Given this list of marker genes INPPL1, RAP1B, GNG10, RNF103, ADD3, ALDH1A1, AHCYL1, ETS2, PCMT1, ARL3, PHOX2A, CALB1, DHX8, ARHGAP11A, YES1, HMGN2, SRSF11, CTH, ARPC5, PIM1, OSBPL9, RPL27A, RAB31, PKNOX1, GTPBP1, VIM, CDK7, MAFG, NLK, HNRNPU, MAN2A2, ST13, SERINC1, MYB (NCBI Gene Id 4602), CELF1, here is a description of the gene set: from publication Dorsam ST, Ferrell CM, Dorsam GP, Derynck MK, Vijapurkar U, Khodabakhsh D, Pau B, Bernstein H, Haqq CM, Largman C, Lawrence HJ (PMID 14604967) HOXA9 targets up-regulated in hematopoietic stem cells. studied in species Homo sapiens Hematopoietic defects in HOXA9(-/-) mice demonstrate a key role for this homeoprotein in blood cell development. Conversely, enforced HOXA9 expression is leukemogenic in mice, and HOXA9 is frequently activated in human acute myeloid leukemia (AML). Although HOXA9 is thought to function as a transcription factor, few downstream targets have been identified. We searched for early HOXA9 target genes by using a transient overexpression strategy in 3 hematopoietic cell lines (2 myeloid, 1 lymphoid). cDNA microarray analyses identified genes whose expression was modulated at least 2-fold. Expression signatures in myeloid and lymphoid cells demonstrated that HOXA9 functions as both an activator and repressor of a variety of genes in cell-specific patterns suggesting that the transcriptional effects of HOXA9 are largely dependent on the cell context. Transient transcription assays and target gene expression patterns in HOXA9(-/-) marrow cells imply that we have identified direct physiologic targets. Many target genes are expressed in CD34+ stem cells or are members of gene families involved in proliferation or myeloid differentiation. Expression of 14 HOXA9 target genes correlated with high-level HOXA9 expression in primary AML. These data suggest that many genes identified in this survey may mediate the biologic effects of HOXA9 in normal and leukemic hematopoiesis. Human Gene Set: DORSAM_HOXA9_TARGETS_UP